The following is a description of a gene set: This study aims at identifying genes that are NIK/NF-kappaB2 responsive in murine dendritic cells matured in vivo. Human Gene Set: GSE7219_WT_VS_NIK_NFKB2_KO_DC_DN Genes down-regulated in dendritic cells: wildtype versus NFKB2. from publication Lind EF, Ahonen CL, Wasiuk A, Kosaka Y, Becher B, Bennett KA, Noelle RJ (PMID 18566401) species: Homo sapiens, and this is the list of marker genes: RNF144A, ARHGAP26, RAP1GAP2, RACGAP1, PHF20L1, SLAMF6, SLC11A2, SGMS1, COPS7A (COP9 signalosome subunit 7A), NLN, RCSD1 (NCBI Gene Id 92241), SH3BP5, FBXO28, LPIN1, MED8, ZSWIM6, PHF13, RASA3, SLC49A4 (NCBI Gene Id 84925, solute carrier family 49 member 4), TTC13, CLDND2, ATP11B, DKC1 (dyskerin pseudouridine synthase 1), ELMO1, IL7R, B3GNT5, OVGP1, CAB39L, UTP14A, NSG2, ADGRL1, NAT10, SMYD1 (NCBI Gene Id 150573), SLC25A27, DTX1, XRN2, SPICE1, KLF3, ARHGAP15 (NCBI Gene Id 55843), MDM4, SCML4, VIPR1, TAGLN2, SLC25A46, TCF7, SETX, SMPDL3B, ARL5C, IQGAP2 (NCBI Gene Id 10788), MUS81 (MUS81 structure-specific endonuclease subunit), S1PR1, POLR3G (NCBI Gene Id 10622), CCND3, UTRN, IL18R1, ZC3H12D, ME2, RASGRP2, BIN2, ATP2B1, DPH5, PHYHD1, CD247, WDR37, ARHGAP5, PPP4R1, ECHDC1, USP33, TRAF5 (TNF receptor associated factor 5), SMAD4, MACF1, PLEK, ADD3, USP53, CNOT6L, FOXP1, PGLYRP1, RNF32, FCGR2B, POLR3B, AP3M1, CYRIA, ARL4C, PDLIM1, EXOC1, RARS2, CYP17A1, RIPOR2, TBC1D22B, PHF21A, GPD1L, MTHFSD, XYLT1, PIK3R5, F2RL2, GPATCH4, AS3MT, TXK, METTL17, GM2A, PDE2A (NCBI Gene Id 5138), HAAO, PLCB2, MTX3, FCHO2, CDC14B, FLNA, TNFSF8, IKBKE, CD84, SPN, NCLN, TLR1, MOB3A, NUDT13, RFX3, LAIR1, PDSS1, POLE2, ITGA4, PRKCQ, PSTK, TNFAIP8L1, EML3, LRRFIP1, GNPTAB, SNX4 (NCBI Gene Id 8723), CCDC125, GPR146, NCK2, ACOT7, IL6R, CD7, IPCEF1, CD27, CMAHP, NFATC3, AQP9, KLRC2, ADAMTS6, FGF13, DGKA, SMAD3, DNAJC15, TSPAN2, CLDND1, CRTAM, BACH2, SELL, SP100, MTAP, GAB3, PUS7L, TOPBP1, FRRS1, KLHL6, IL18RAP, GGT1, CD302, SIDT1, ATP8B4, PPP2R5C, POGK, PIK3IP1, RCBTB1, PIGV, CD55, ANAPC16, YEATS2